Given this list of marker genes TNFRSF13B, C3orf80, SH3PXD2A, PATL2, MRPS10, IFT80, LRRC57, TLR1, C3orf70, IGHM, QKI (NCBI Gene Id 9444), PIM1, BID, N4BP2, FCMR, TFRC, SNX14, PENK, CD72, TNFRSF18, SLC22A2, DUSP4, PIWIL4, IL17RB, TNFRSF4, ZPBP2, GPX7, PEAK1, PPP1R3F, UBASH3B, ETV5, PHLPP1, BCLAF3, SULF2, GSTM4, EPHX1, SLC25A33, IGKC (NCBI Gene Id 3514), IGF2BP3, IL1RL1, SEC16B, TMF1, LTA4H, MYO1E, SELL, TANC2, NDRG1, SLC14A1, MPP1, RRAGD, NDFIP2, SAMHD1, CTPS1, MSRB2, CNKSR3, NTN1, IGSF8, NUCB2, KLC3, ZSCAN12, ENO3, SRSF2, RIN2, CCS, LRRC61, GSTO1, CPEB4, CHML, PHTF2, SLMAP, ATP11B, VAV2, CHDH, P4HA1, PTCH1, CD81, FAM221A, GBP4, SYNCRIP, ARL16, HLA-DOB, IZUMO1R, HBS1L, SHISA5 (NCBI Gene Id 51246), ARL5A, DRC1, ENO2, CSRP2, SNX9, TGFBR1, CISH, TENT5A, PTS, TRIM59 (tripartite motif containing 59), MIER1, SMC4, SWAP70, PTPRS (NCBI Gene Id 5802), MAN1A1, PPM1L, TMEM158, INPP5A, LCA5, COL15A1, USP47, GOLM2, SLC25A19 (NCBI Gene Id 60386), DCTD, ACER3, TMEM237, SDC4, ACOT9, P2RX4, PHC3, MED7, PIK3R3, PPA1, SLC7A7, BTF3L4, GPR83, DNAH7, PARD6G, TPST1, IGLC7, CDC14A, MYC, NCOA3, SCAMP1, GNPNAT1, TP53BP2, SLC2A3, FOXP3 (NCBI Gene Id 50943), FRMD6, LARP1, VRK1, AKAP7, PRG4, ADSS2, SOCS2, ENTPD1, RAPGEF5, NCMAP, GFPT1, ITGA6, CYB5A, GNG12, AK7, ATP6V0A1, FAM3C, RHOH, NDRG2, CAMKK1, BCL2L1 (NCBI Gene Id 598), ZDHHC20, MGST2, SYPL1, LRRC58, ETFBKMT, NOP58, MBNL3, ITGB8, TNFRSF9, PHC1 (polyhomeotic homolog 1), EIF5A, TLE2, SESN1, RBMS1, TIMM8A, SEC24A, DNAI4, RASGEF1A, CMTM7, WWP1 (NCBI Gene Id 81891), ASXL1, WLS, KHDRBS1, CAPZA2, IL2RB, CC2D2A, ECM1, CBL, ERGIC2, FCGR2B, ITIH5, CD79B, NEDD4L, SELENOI, CD83, CDKN2AIPNL, NEB, SLC35D1, GRAMD1C, EXOSC8, GBP7, IKZF4, DGAT2, CDC27, LCLAT1, SCD, TWSG1, here is a description of the gene set: studied in species Homo sapiens from publication Feuerer M, Hill JA, Kretschmer K, von Boehmer H, Mathis D, Benoist C (PMID 20231436) Human Gene Set: GSE20366_TREG_VS_NAIVE_CD4_TCELL_UP Regulatory T (Treg) cells that express the FoxP3 transcription factor are essential for lymphoid homeostasis and immune tolerance to self. Other non-immunological functions of Treg cells, such as controlling metabolic function in adipose tissue, are also emerging. Treg cells originate primarily in the thymus, but can also be elicited from conventional T cells by in vivo exposure to low-dose antigen or homeostatic expansion, or by activation in the presence of TGFβ in vitro. Treg cells are characterized by a distinct transcriptional signature controlled in part, but not solely, by FoxP3. For a better perspective on transcriptional control in Treg cells, we compared gene expression profiles of a broad panel of Treg cells from various origins or anatomical locations. Treg cells generated by different means form different sub-phenotypes identifiable by particular combinations of transcripts, none of which fully encompass the entire Treg signature. Molecules involved in Treg effector function, chemokine receptors, and the transcription factors that control them are differentially represented in these subphenotypes. Treg cells from the gut proved dissimilar to cells elicited by exposure to TGFβ, but instead they resembled a CD103+Klrg1+ subphenotype preferentially generated in response to lymphopenia. Genes up-regulated in comparison of TregLP versus TconvLP (see Table 1S in the paper for details).